Given this list of marker genes Dll4, Rps27a, Dll1, Ubb, Notch3, Psenen, Wwp2, Egfr, Psen1, here is a description of the gene set: This event has been computationally inferred from an event that has been demonstrated in another species.<p>The inference is based on the homology mapping from PANTHER. Briefly, reactions for which all involved PhysicalEntities (in input, output and catalyst) have a mapped orthologue/paralogue (for complexes at least 75% of components must have a mapping) are inferred to the other species. studied in species Mus musculus Reactome Pathway: Signaling by NOTCH3 part of: Signaling by NOTCH electronically inferred by orthology from the curated human pathway